The following is a description of a gene set: species: Homo sapiens Thirty to 60% of CD56dimCD16bright NK cells in healthy adults express CD57, which is not expressed on immature CD56bright NK cells or fetal and newborn NK cells. We hypothesized that CD57+ NK cells within the CD56dim mature NK cell subset are highly mature and might be terminally differentiated. We used microarrays to assess the transcriptional differences between CD57+ and CD57neg NK cells within the CD56dim mature NK subset. Genes down-regulated in NK cells: B3GAT1+ versus B3GAT1-. from publication Lopez-Vergès S, Milush JM, Pandey S, York VA, Arakawa-Hoyt J, Pircher H, Norris PJ, Nixon DF, Lanier LL (PMID 20733159) Human Gene Set: GSE23695_CD57_POS_VS_NEG_NK_CELL_DN, and this is the list of marker genes: LARP4, PLCL2, MOAP1 (NCBI Gene Id 64112), SLC16A6, HYLS1, SKI, PSPH, VCL, FCF1, PCCA, PRCC, DNAAF2, OSBPL9, SMG8, CAMK2N1, ABCA1, CLDN15, ABHD3, CLIC4 (NCBI Gene Id 25932), CRAMP1, FAM76B, SDHC (succinate dehydrogenase complex subunit C), PTGS2, SCAMP2, PLK3, CS, RPAIN, ZBTB43, MAP3K8, GPT2, DHCR24 (NCBI Gene Id 9800), CLN3, HYCC2, SUPT4H1, BCO2, TAF3, DDT, DDI1, TERF2IP, BRD2, SIMC1, FADS1, C2orf42, ZFTRAF1, TTC39B, TOP3A, GADD45G, ATF2, GADD45A, CHD7, FAM20C, SNAPC2, GABPA, FIZ1, TRAPPC9 (trafficking protein particle complex subunit 9), TMEM97, NDUFA2, UBN1, GTF2F1, PSME3IP1, EMC4, TAF13, KDM7A, HSPA1B, MANBA, CHCHD6, GPBP1 (GC-rich promoter binding protein 1), F11R, CHD2, STMN1, CDR2, FBXL3, ARID4A, MASTL, JMY, PDRG1, PITRM1, CIR1, CDKN2D, CITED2, CCNK, HES1, DDX47, SLC5A6, SGTB, ACVR2A, TOLLIP, CDK2AP2, CLP1, PIK3C2A, CAPG, WDR53, H2BC5, C5orf15, SLC16A10, KDM6B, IDH3B, CAMK1D, NADK2, PLAC8 (NCBI Gene Id 95621), NAMPT, AMHR2, TFPT, KLHDC10, PIGS, SCAI, CREB3L2, SLC49A4, B4GALT1, ASAH1, MRPL35 (mitochondrial ribosomal protein L35), STAG2, SOAT2, TAX1BP1, TPK1, MINDY2, EMSY, UBC, ACLY, MAFF, ACYP1, CACNG3, GTF2H1, AKR1B1, UBTD1, ARL4A, TAFA2, RELCH, APOE, RB1CC1, SMPDL3A (NCBI Gene Id 10924), YTHDF1 (YTH N6-methyladenosine RNA binding protein F1), MDH1B, RAB20, TMEM170B, MFSD11 (NCBI Gene Id 79157), TNRC6C, YAF2, KIAA1958, RNF167, CHML, DENND5A, MCEE, PTCH1, SLC41A1, MAP1LC3A, LEF1, PAIP2, SLC39A8, NDUFAF5 (NCBI Gene Id 79133), RAB40C, ATF7 (activating transcription factor 7), ABHD5, MARCHF5, SLC28A2, RHBDD3, COX17, PAK1, SEC23IP, MAP3K1 (mitogen-activated protein kinase kinase kinase 1), GEM, EPHA2, CASP4, GPR155, SLC23A3, WDFY4, CDKN2C, MCFD2, CDCA5, SORD, ZHX1, ATP6V1A, SPDL1 (NCBI Gene Id 54908), PLAT, CCDC77, BRPF1, MRPL45, COPZ2, CCNG2, TRIM69, SON, MLXIP, PDGFA, HAUS5, CNTD1, CAPRIN2 (NCBI Gene Id 84116), PPP1CA, UAP1, NANOS1, GPAT3, TMEM176A, TRIP10, UBE4B, CCDC93, RASSF8, ERP44, NBDY, SAP30L, FAM53C, SSR2